Given this list of marker genes Nudt21, Hes5, Hes1, Sos1, Flcn, Sos2, Fnip1, Notch1, here is a description of the gene set: Any process that modulates the frequency, rate or extent of pro-B cell differentiation. species: Mus musculus Mouse Gene Set: GOBP_REGULATION_OF_PRO_B_CELL_DIFFERENTIATION